The following is a description of a gene set: Dolichyl pyrophosphate Man9GlcNAc2 alpha-1,3-glucosyltransferase (ALG6) normally adds the first glucose moiety to the lipid-linked oligosaccharide precursor (LLO aka N-glycan precursor) which is required for subsequent N-glycosylation of proteins. Defects in ALG6 can cause congenital disorder of glycosylation 1c (ALG6-CDG, CDG-1c; MIM:603147), a multisystem disorder characterised by under-glycosylated serum glycoproteins. ALG6 deficiency is accompanied by an accumulation of the N-glycan precursor (GlcNAc)2 (Man)9 (PP-Dol)1 and is the second most common CDG disease subtype after PMM2-CDG (CDG-1a). CDG type 1 diseases result in a wide variety of clinical features, such as defects in the nervous system development, psychomotor retardation, dysmorphic features, hypotonia, coagulation disorders, and immunodeficiency. Reactome Pathway: Defective ALG6 causes CDG-1c studied in species Homo sapiens part of: Diseases associated with N-glycosylation of proteins, and this is the list of marker genes: ALG6